The following is a description of a gene set: species: Mus musculus Mouse Gene Set: GOMF_HISTONE_H3K9ME2_H3K9ME3_DEMETHYLASE_ACTIVITY Catalysis of the removal of a methyl group from a tri or a dimethyl-lysine residue at position 9 of the histone H3 protein. This is a dioxygenase reaction that is dependent on Fe(II) and 2-oxoglutarate., and this is the list of marker genes: Kdm1a, Kdm4c, Kdm4d, Kdm4a, Kdm4b